Given this list of marker genes MTOR, JMJD8, SDHAF3, SESN2, FMO1, ACACB, MIR182, IGF1, BMP5, DDIT4 (DNA damage inducible transcript 4), ABCD2, PHKA1, GUCA1A, FMO5, MBTPS2, GPLD1, ZMPSTE24, NUPR1, MIR27A, HDAC4 (NCBI Gene Id 9759), PARP1, DCAF5, DYRK2, ABCD1, IGFBP3, NCOA2, DNAJC30, MIR103A1, STAT3, IFNG, GGCX, MLXIPL, GNAI1, GFI1, SLC4A4, PPARGC1A, WNT4, MIR204, SIRT4, PRXL2C, AMDHD2, SERPINA12, ATPSCKMT, PPTC7, MIR210, BRCA1, GSK3A (NCBI Gene Id 2931), DKKL1, TFF3, ERLIN2, TREM2, PTH, MIR21, PTPN2, CEACAM1, CLN3, APOA5 (apolipoprotein A5), MTCH2, GDF15, NR0B1, PLIN5, ACADVL, LPCAT3, KAT2B, VCP, LEPR, KIT, FABP5, LONP2, INSR, MIR96, FMO4, PRKAG2, PPP4R3A, SIRT7, MFSD2A, MIR98 (microRNA 98), AVPR1B, PPARG, ATP5IF1, SORBS1, IRS2, MALRD1, ACADM, PRKN, ACMSD, AKR1C3, PIBF1, HTR2A (5-hydroxytryptamine receptor 2A), TRIB3, RDH10, AVPR1A, TCF7L2, PPP4R3B, PSEN1, ME1, SLC7A7, MLST8, PRKAG3, SIRT6, BHMT, FOXK1, CREB1, APPL2, PLAA, PPP1R3E, FH, ADIPOQ, ADCYAP1R1, REST, CDA, NR1H2, SNAI2, ME2, IER3, MAPK1, PLEK, PFKFB1, DKK3, PRKAA2, MIR548P, APOC1, CES1, FGFR4, MIR27B, P2RX7, BMP6, IGF2, CAV1, PHKG2, PRKAA1, AGT, CLK2, DNM1L, NR1H4, LCMT1, WDR5, PRKG1, APOE, PPP2CA, BCKDK, P2RY6, ALDOB, MIR132, CPT1A, PRKACA, SIK1, PID1, ZNF692, GNMT, PRMT3, BMP2, MIR107, AQP8, FOXO1, IGFBP4, FGF19 (fibroblast growth factor 19), PANK2 (pantothenate kinase 2), NR1H3, ABCA2, SPHK2, ARPP19, GMPPA, NFE2L1, SREBF2, PGK1, ERLIN1, TSPO, TTC39B, TIGAR, RD3, NTSR1, UGT1A4, UGT1A10 (NCBI Gene Id 54575), C7orf50, ETFBKMT, PPP1R3G, MST1, GPD1, TMSB4X, SIRT2, NFKB1, PROX1, PTH1R, GPRC6A, ZBTB20, APOA4, CLCN2, SIRT1, UGT1A7, GPER1, DGAT2, STARD4, TP53, PPP1CA, UGT1A1, MLYCD, PDK1, LMF1, HNF4A (hepatocyte nuclear factor 4 alpha), MTCL2, ANGPTL4, INS, FMO2, PPP1R3B, ATCAY, ADIPOR1, USP7, ARL2, WDTC1, ABCG1, APOB, P2RY1, SLC35B4, FLCN, EGR1, RANBP2, LACC1, FABP3, NR1D1, RORC, QKI, SLC22A13, UCHL1, BEND3, C1QTNF1, PDK2, SELENOS, GIP, PLA2G3, SRC, TREX1, NR3C1, GCHFR, ELOVL5, TWIST1 (twist family bHLH transcription factor 1), ANTKMT, TRIM63, GCG, TNF, TYSND1, GPIHBP1, IL1B, INSIG2, ZFP92, DDB1, HIF1A, SLC45A3, PTGS2, APOC2, KPNB1, MIR675 (microRNA 675), SIRT5, NNMT, PPARA, ACTN3, ABCG4, GCK, HMGB1, UGT1A6, MTLN, UGT1A8, H6PD, MBTPS1, C1QTNF3, MAP2K1, FBP1, GPR146, LHCGR, GAPDHS, MIR766, APOC3, SCAP, MID1IP1, AKT1, IL4, PPARD, PDK4, LEP, FGF1, C1QTNF12, GIT1, SREBF1, TAFAZZIN, SEC14L2, SOX9, MACROH2A1, ARNT, ARV1, SLC7A11, LDLR, APP, APOA1, EP300, ZBTB7A, ADCY10, RORA, MIR342, ACADL, LPGAT1 (NCBI Gene Id 9926), CBFA2T3, UBR4, BGLAP, SNAI1, ENO1, AKT2, PDK3, CLYBL, AVP, PARK7, ADM, GNB3, IRS1, CD74, DGKQ, GUCA1ANB-GUCA1A, EPHX2, ERFE (NCBI Gene Id 151176), EPM2AIP1, UGT1A9, NLN, CD244, INSIG1, FOXK2 (NCBI Gene Id 84213), CRY1, FIS1, PMAIP1, EIF6 (eukaryotic translation initiation factor 6), SLC2A6, AGTR1, PGP, OGT, ABCB11, STAR, CYP7A1, DAB2, MIR30C1, MIR185, UGT1A3, ADCK2, CD320, RPTOR, PRKAG1, SNCA (synuclein alpha), SLC4A1, ATP2B4, KLHL25, NCOR1, LDLRAP1, CH25H, MIR33A, GHSR, PINK1, TPK1, KAT2A, NDUFC2, PAQR3, here is a description of the gene set: studied in species Homo sapiens Human Gene Set: GOBP_REGULATION_OF_SMALL_MOLECULE_METABOLIC_PROCESS Any process that modulates the rate, frequency or extent of a small molecule metabolic process.